The following is a description of a gene set: from publication Ramilo O, Allman W, Chung W, Mejias A, Ardura M, Glaser C, Wittkowski KM, Piqueras B, Banchereau J, Palucka AK, Chaussabel D (PMID 17105821) Each infectious agent represents a unique combination of pathogen-associated molecular patterns that interact with specific pattern-recognition receptors expressed on immune cells. Therefore, we surmised that the blood immune cells of individuals with different infections might bear discriminative transcriptional signatures. Gene expression profiles were obtained for 131 peripheral blood samples from pediatric patients with acute infections caused by influenza A virus, Gram-negative (Escherichia coli) or Gram-positive (Staphylococcus aureus and Streptococcus pneumoniae) bacteria. Thirty-five genes were identified that best discriminate patients with influenza A virus infection from patients with either E coli or S pneumoniae infection. These genes classified with 95% accuracy (35 of 37 samples) an independent set of patients with either influenza A, E coli, or S pneumoniae infection. A different signature discriminated patients with E coli versus S aureus infections with 85% accuracy (34 of 40). Furthermore, distinctive gene expression patterns were observed in patients presenting with respiratory infections of different etiologies. Thus, microarray analyses of patient peripheral blood leukocytes might assist in the differential diagnosis of infectious diseases. Human Gene Set: GSE6269_FLU_VS_E_COLI_INF_PBMC_DN Genes down-regulated in comparison of peripheral blood mononuclear cells (PBMC) from patients with acute influenza infection versus PBMC from patients with acute E. coli infection. species: Homo sapiens, and this is the list of marker genes: NXF1, FBLN2, RPS14, EIF4B, UBA52, RPL3, CRHR1, KLK3, GABRQ, RAMP2 (receptor activity modifying protein 2), BTF3P12, EFNB2, PDGFRA, MAGEA10, MAPT, MAP2K3, DELE1 (DAP3 binding cell death enhancer 1), DKK4, OVOL1, C8B, FOXJ2, NAP1L1, QARS1, PDAP1, OBSCN, P3H2, ATP2B2, APOC1, DBH, RPL21P2, GSTZ1, PTPRD, GYPC, RPL23, FGFR2, GAGE1, RPSAP20, ATP8A2, RPL13A, SEPTIN7, MYL11, THNSL2, MYCN, RPL36AP52, EIF3D, PRRG3 (NCBI Gene Id 79057), CDKN2A-AS1, GJD2, EHD2, KCNE1, KCNA10, GABBR2, NPFFR1, NDRG4, FNDC8, TP53AIP1, BMP7, PDE7B, ST8SIA3 (ST8 alpha-N-acetyl-neuraminide alpha-2,8-sialyltransferase 3), DOCK6, RPL10L, MOK, RPL7P27, PABPC4, DUSP9, KRT12, SLC2A1, EIF3F, MAN2B1, DNAJB5, MAP2K5, KRT76, EEF2, SLC7A8, MECOM, DUS2, FGL1, CASP2, SULT1E1, RPL26P36, CP, TRO, BCAM (basal cell adhesion molecule (Lutheran blood group)), LZTS1 (NCBI Gene Id 11178), NTRK1, ACSBG1, SPTBN1, GPR143, CCNI, ESR2, ADAM19, CELP, EEF1A1P42, FXYD2, EDN3, RPL23AP22, CD44, RPL10P2, LOX, AFDN, CA12, PRSS3P2, CSNK1D, RPL13, KIF25, SNORA70, YBX3, RPS4XP3, EIF3L, FBL, B9D1, RPS5 (NCBI Gene Id 6193), RPL22, PCBP2, EPHB1, SH3PXD2A, GRAPL-AS1, RPL7P52, RPS10P5, AP3B2, FABP1, RPL7, AGRN, KIF17, RPL5, RPL15P22, EEF1B2, EVPL, NPHP4, BTF3 (basic transcription factor 3), RPL6P17, SLC25A5, PART1, GNL3L (NCBI Gene Id 54552), TSKU, SLC4A3 (NCBI Gene Id 7858), KLK12, COX4I1, LYRM4, FRMD1, FTCD, KRT1, RPS4XP2, RPS3AP5, CALD1, PDE4C, DNAH6, RPS3A, RPL31, WNT10B, CKMT2, TF, ST13, FOXA2, SERPINA4, MYH11, RPL4, KCNJ12, TH, NPM3, RPL29, NECTIN1, CCN4